The following is a description of a gene set: An abnormally elevated blood pressure in the circulation of the pulmonary artery. Human Gene Set: HP_ELEVATED_PULMONARY_ARTERY_PRESSURE species: Homo sapiens Elevated pulmonary artery pressure, and this is the list of marker genes: NDUFB10, LIFR, LMNA, MT-TH (mitochondrially encoded tRNA-His (CAU/C)), TLL1, SFTPA2, THPO, TRRAP, ZNF699, MT-TS2, HBB, ACTA2, NOTCH1 (NCBI Gene Id 54781), CHST3, MYH7, KMT2D, PIGN, DLK1, NKX2-1, TERT, COX5A, CLXN, CAPNS1, ENG, SFTPB, ALDH1A2 (aldehyde dehydrogenase 1 family member A2), CACNA1D, KRT18, COX8A, ABCD4, TCIRG1 (NCBI Gene Id 8845), IL6, COG1, EIF2AK4, PDSS1, MT-TL1, PRIM1, MMACHC, HLA-B, MT-ND5, ATP13A3, ACTC1, IFT56, MT-TQ, MUC5B, SMAD4, UBE2A, MT-TF, FBXL4, LIPT1, TNFSF11, IPO8, PRDX1, COLQ, VPS33A, HLA-DRB1, CACNA1C, MT-TW, MT-CO1, SFTPC, GATA4, PSMB9, CCN2, LARS2, TBX4, THSD1, ATP5F1A, LAMB2, KDM6A, MIF, ALMS1, COL1A2, STAT1, SCARB2, BMPR2, NDUFA8, NAA10, FLNA, RPL3L, CLCN7, CITED2, FBN1, DEF6, FOXP1, NKX2-5, HSPG2, COL1A1, TBX20, KIAA0319L, FIG4, JAK2, DOCK6, MT-ND1, PAM16, CTCF, LACC1, MT-CO2, IRF5, ABCA3, MGP, MT-ND6, SNX10, COX6B1, MYH11, CCR6, MT-CO3, SLC25A24, MED12 (NCBI Gene Id 9968), MYBPC3, PPCS, VAC14, SOX9, MYMK, VCL, AFF4 (NCBI Gene Id 27125), AGR2, RTL1, GDF2, VHL, MT-ND4, PGM1, EFEMP2, BTNL2, GATA6 (GATA binding protein 6), FOXF1, ABCC6, SARS2, IL6ST, KCNK3, FGFR3, G6PC3, ERI1, MPL, NOD2, IDUA, COX7B, MEG3, TBX5 (T-box transcription factor 5), IL12B (interleukin 12B), KRAS, ADAMTSL2, MYH6, MED25, ZMPSTE24, FGFR1, NF1, LAMA2, GBA1, SLC29A3, SMARCAL1, DLL4, ARHGAP31, ENPP1, SMAD9, SLC37A4 (NCBI Gene Id 84965), ACVRL1, RBPJ, BANF1, EOGT, CA2, AGK, ARSB, ODAD1 (outer dynein arm docking complex subunit 1), MLX, NFIX, IKBKG, CAV1, NFU1